Given this list of marker genes Zdhhc17, Tgfbi (transforming growth factor, beta induced), Tsga10, Stag2, Rsad2, Map3k1, Nkiras1, Frat1, Bcl7a, Spry2, Epha4, Pan3, Smad7, Lsm5, Armcx5, Ppp1r3b, Mindy2, Ski, Pja2, Zfp229, Pbrm1, Hipk3, Scml2, Caskin1, Bcl11b, Mprip, Il12a, Ubr3, Pitx2, Rasgrp1, Fnip1, Prkci, Map2k3, Vcl, Ank2, Ndufv2, Fgd4 (NCBI Gene Id 320417), Yap1, Yod1 (NCBI Gene Id 76190), Hnrnpk, Ndnf, Necab1, Sema5a, Rbms3, Dmrtc2, Ube2d3, Pik3r1, Edil3, Nfib, Matn2, Spink14, Rab11a, Ppp1r3a, Glis2, Ranbp3l, Sc5d, Ccl20, Pcbp2 (poly(rC) binding protein 2), Plxna2, Akap6, Zfp367, Fa2h, Fmn1, Fasl, Cwh43, Edrf1, B3galt1, Ipo11 (importin 11), Gm4894, Il21, Gramd2b, Hnrnpu, Fgf18, Jph1, Mbd4, Ehd1, Elf2, Adgrg2, Dlgap1, Rmnd5a, Ankrd49, Dvl2, Acvr2a, Sox5, Zfp955b, Pcsk6, Tmem170, Slc30a10, Tmem236, Reck, Btg2, Arhgap24 (NCBI Gene Id 75397), Nfia, Srl, Pdcd4, Crebrf, Ifrd1 (NCBI Gene Id 15982), Cpeb3, Acsm2, Osr1, Dusp8, Zfp27 (NCBI Gene Id 22689), Ccl1, Ntf3, Spry1, Armcx1, Mreg, Pnpt1, Tmtc3, Tent5a, Kdm7a, Pcmtd2, Peli1, Tipin, Nectin3, here is a description of the gene set: studied in species Mus musculus from publication Chen Y, Wang X (PMID 31504780) Genes predicted to be targets of miRBase v22 microRNA mmu_miR_21c in miRDB v6.0 with MirTarget v4 prediction scores > 80 (high confidence targets). Mouse Gene Set: MIR_21C